The following is a description of a gene set: studied in species Homo sapiens Human Gene Set: MIR4676_3P Genes predicted to be targets of miRBase v22 microRNA hsa-miR-4676-3p in miRDB v6.0 with MirTarget v4 prediction scores > 80 (high confidence targets). from publication Chen Y, Wang X (PMID 31504780), and this is the list of marker genes: SF3B1, GJA1, PGM2L1 (phosphoglucomutase 2 like 1), LAMC1, NFE2L3, CACNA2D1, KBTBD3, NOC3L, ANKS1B, OIT3, CNOT11 (CCR4-NOT transcription complex subunit 11), NKX6-3, CDK17, COMMD9, HMGB3, CHD2, SEC61A2, BBX (BBX high mobility group box domain containing), GAN, DYRK1A, SCX, SS18L1, TMOD2, RNF139, RAB42, FAM120A2P, SEC63, TES, TLL1, TFAP2B, LIFR, EXOSC3, NCOA7, TMEM87A (transmembrane protein 87A), BDP1, TIMP3, PACSIN2, FAM8A1, ZDHHC21, PTPRR, TENT4B, EPS8, ARHGEF10, RPS16, HOMEZ, PRKAR2B, ENSG00000277067, SIAH1, ELAVL4, YIPF6 (Yip1 domain family member 6), PDE10A, TNPO1, STAM2, LINC03104, RPS6KA3, PIP4P2, TMED7, TYW5, PURA, SRCIN1, SERINC1, SIPA1L1, VPS41, RASGRP1, ZNF644, GRM3, CEP350, RBFOX1, ARMC10, AGMO, UPF1, GSDME, ASCC1, KCNK2, SYPL2, SUPT6H, PHF6, DACT1, ALG2, PLPP6, NPHP1, SMAD4, PKN2, SOX7, RAB21, SNX18, PLAG1, C5orf24, SRD5A3, PPA2, ANAPC4, LINC03105, XKR6, DPY19L1, GNPTG, MZF1, SUMO3, PPP1R10 (NCBI Gene Id 5514), KCNH5, AVL9, DISC1, BZW1, APBA3, CD1E, HS3ST3B1, LEF1, XKR8, ZNF692, DISP2, COLEC12, SEC23A (SEC23 homolog A, COPII coat complex component), CAPN7, VEZT, ADD3, TIMP2, PAN3, CRKL, PIGK, MAP3K20, BROX, GPR173, CDKN1B (cyclin dependent kinase inhibitor 1B), TNFSF13B, GUF1, RIMKLB, FGD4, MAPRE1, FILIP1L, SCAI, TENM1, CTCFL, LIG4, ARF4, HP1BP3, SPRYD7, GABPA, KCTD15, CNPPD1, DCLK1, UBA6, DR1, NFIB, ARIH1, CTTNBP2, RYK, C3orf70, GALNS, AFF4 (NCBI Gene Id 27125), SON, UBE2D1, PPP3CB, TSPYL5, ERC2, MTMR6, SULF1, ANKRD17, IMMP2L, ZNF621, INTS8, ANKRD27, CCL23, CREB5, DNAI7, AKAP5, PNN, SLC27A6, TTC21B, NDST3, CCNO, SERTAD2, YWHAE, SLC7A11, BRDT, FSD1L, INKA2, GARNL3, ERI2, NAP1L5, ESS2 (ess-2 splicing factor homolog), PTPRJ, JADE1, DSG3, SP3, IGIP, LXN, HORMAD1, LRP1B, MBOAT2, GIN1, ELAPOR2, WDR17, BICD2, ANK2, SNRPD3, HAT1, MRPS23, BECN1, RIC1, ZNF140, EXOC4, PAQR9, RORA, SMIM12 (NCBI Gene Id 113444), CNTN3, TMEM232, MKLN1, CASD1, GPR75, SNAI2, RPA1, SERP1